Given this list of marker genes UEVLD, ARL6IP1, CELSR3, CD300LG, DNAH10, HR (HR lysine demethylase and nuclear receptor corepressor), TBC1D2, RCHY1, NPBWR1, FLCN, TM4SF18, BRD7P3, CR1, NEUROG3, ARF5, MYRFL, IMPA2, RAB8A, MYH10, SLA, IL13RA2, SEPTIN12, PKD1L2, MAB21L3, KPNA5, ENC1, OPN5, LRRN4CL, TCAIM, ZC3H12C, PAX7, PAIP2B, LTBR (lymphotoxin beta receptor), TCHP, KSR2, FADD, ANKRD42, MOBP, MRAP2, DUSP18, HOXA11, CEBPA-DT, SUGT1P1, CCL2, DTWD2, PYGO1, JAK1, GZF1, WFDC21P, ETV6, FAM182B (family with sequence similarity 182 member B), TMEM150B, KIR2DL4, ENSA, ELSPBP1, CAMKV, PURB, SMOX, FZD4, NFE2L3, ETV7, CLCN3, ASF1A, CFAP45, NEU4, GUCY1B2, PTPN22, LRRC38, OR51I1, KISS1, IWS1, PRRT3, STAG3, MYCBPAP, LLCFC1, CGNL1, NLRP8, A4GALT, SLC16A1-AS1, BMP15, PPM1N, PPP1R37, FOXRED2, PDGFB, KLLN, C20orf203, CLSTN2, ADAD1, CTSE, CD3G, RNASE3, SIGLEC8, FGF1, PURG, DLX6-AS1, KCNH4, ALDH1L2, PDZK1, BBOX1 (gamma-butyrobetaine hydroxylase 1), NDUFAF3, UGT2B28, KCNK4, LINC02297, CCZ1, RNF112, TMSB15B-AS1, EHD3, NFATC1, UPK1B, SMYD4, FANCD2OS, GLRA2, CYP17A1, TRHDE, CDH4, CDK9, LAMA4, BCKDK, TMEM50B, PPM1M, MMP2, FBXO39, LINC00607, DUSP16, S1PR2, LGALSL, ZKSCAN7, SMIM20, CPA3, RUVBL1, RASIP1, CARMIL2, CLIC2, LINC00470, CD163, LINC00589, MFSD4B (major facilitator superfamily domain containing 4B), NBPF3, POLH, TRIM67, BMX, AK5, PCA3, PACRG, CBX6, TRNP1, PRKAR1B, PDE6G, ZNF30, ZFAND4, MTTP, LRRC27, PKD1L1, HCAR1, TSPAN4, CPSF7, ENSG00000228919, HOXC13, DPPA5, ESPNL, EMX2OS, DUSP15, ENDOV, TBXAS1, OCM2, GSX1, SMR3B, KISS1R, HUNK, MYOM1, F13B, THAP8, NHERF2, ARHGAP24, TIMM23B, KITLG, LCAT, OR7E24, LMOD3, TBKBP1, DGCR5, CCDC144NL-AS1, ZNF575, CCT6B, PTCSC1, FZD1, LINC01192, PGC, RNF208, RHOD, PRR15, CNDP1, here is a description of the gene set: studied in species Homo sapiens from publication Marigo I, Bosio E, Solito S, Mesa C, Fernandez A, Dolcetti L, Ugel S, Sonda N, Bicciato S, Falisi E, Calabrese F, Basso G, Zanovello P, Cozzi E, Mandruzzato S, Bronte V (PMID 20605485) Genes up-regulated in CD11b Spleen from C57BL6 mouse versus CD11b Tumor from C57BL6 mouse. Human Gene Set: GSE21927_SPLEEN_VS_TUMOR_MONOCYTE_C57BL6_UP Tumor growth is associated with a profound alteration of myelopoiesis, leading to recruitment of immunosuppressive cells known as myeloid-derived suppressor cells (MDSCs). Analyzing the cytokines affecting myelo-monocytic differentiation produced by various experimental tumors, we found that GM-CSF, G-CSF, and IL-6 allowed a rapid generation of MDSCs from precursors present in mouse and human bone marrow (BM). BM-MDSCs induced by GM-CSF+IL-6 possessed the highest tolerogenic activity, as revealed by the ability to impair the priming of IFN- -producing CD8+ T cells upon in vivo adoptive transfer. Moreover, adoptive transfer of syngeneic, GM-CSF+IL-6-conditioned MDSCs to diabetic mice transplanted with allogeneic pancreatic islets resulted in long term acceptance of the allograft and correction of the diabetic status. Cytokines inducing MDSCs acted on a common molecular pathway. Immunoregulatory activity of both tumor-induced and BM-derived MDSCs was entirely dependent on C/EBP transcription factor, a key component of the emergency myelopoiesis triggered by stress and inflammation. Adoptive transfer of tumor antigen-specific CD8+ T lymphocytes resulted in therapy of established tumors only in mice lacking C/EBP in myeloid compartment. These data unveil another link between inflammation and cancer and identify a novel molecular target to control tumor-induced immune suppression. We used gene expression analysis to identify those factors, secreted by tumor-infiltrating MDSC, which could drive emathopoiesis. Moreover we compare gene expression profile of tumor-induced MDSC, obtained from either the spleen and the tumor infiltrate of tumor bearing mice, and in vitro bone marrow-derived MDSC.